The following is a description of a gene set: Human Gene Set: HP_RECURRENT_APHTHOUS_STOMATITIS species: Homo sapiens Recurrent episodes of ulceration of the oral mucosa, typically presenting as painful, sharply circumscribed fibrin-covered mucosal defects with a hyperemic border. Recurrent aphthous stomatitis, and this is the list of marker genes: IFNGR1, KLRC4, ERAP1, MEFV, IL6, HYOU1, ORAI1, STAT4 (signal transducer and activator of transcription 4), RORC, CASP10, CCR1, HLA-B, RNF125, SEC61A1, HLA-DQA1, FAS, IL12A-AS1, IL12A, GFI1, NLRP3, CLPB, SRP19, IL10, STK4, RIN2, WDR1, IL23R, PRKDC, NOD2, NCF4, TCIRG1, TLR4, IL17RC, TLR8, MVK, C4A, ELANE, DCLRE1C, HLA-DQB1, FASLG, UBAC2, NLRP12, TICAM1, MALT1, CEBPE, CARMIL2